Given this list of marker genes Dcp1a, Btg2, Pan2, Zfp36l3, Cnot6l, Patl1, Tnrc6a, Dcps, Hnrnpu, Cnot2 (CCR4-NOT transcription complex, subunit 2), Polr2g, Lsm1, Pan3, Csde1, Zfp36l1, Paip1, Samd4b, Rc3h2 (NCBI Gene Id 77277), Tob1, Dcp2, Cnot7, Hnrnpd, Zfp36l2, Ago2, Cpeb3, Pnldc1, Pabpn1l (poly(A)binding protein nuclear 1-like), Cnot3, Cnot8, Caprin1, Noct, Igf2bp1, Tnrc6b, Dcp1b, Pde12 (NCBI Gene Id 211948), Tnrc6c, Cnot1, Syncrip, Parn, Tent4a, Mlh1, Rc3h1, Samd4, Ybx1, Patl2, Tent4b, Dhx9, Pabpc1, Dhx36, Eif4enif1, Cnot6 (NCBI Gene Id 216722), Zfp36, here is a description of the gene set: studied in species Mus musculus A major pathway of degradation of nuclear-transcribed mRNAs that proceeds through a series of ordered steps that includes poly(A) tail shortening and that can regulate mRNA stability. Mouse Gene Set: GOBP_NUCLEAR_TRANSCRIBED_MRNA_CATABOLIC_PROCESS_DEADENYLATION_DEPENDENT_DECAY